Given this list of marker genes Dkc1, Exosc4, Tent4b, Larp7-ps, Exosc3, Exosc5, Larp7, Parn, Exosc2, Fbl, Exosc10, Exosc6, Rnf113a1, Rnf113a2, Fbll1, here is a description of the gene set: Mouse Gene Set: GOBP_SNO_S_RNA_PROCESSING Any process involved in the conversion of a primary snoRNA family RNA transcript into a mature snoRNA (eukaryota) or sRNA (archaea). species: Mus musculus